The following is a description of a gene set: Any process that modulates the frequency, rate, or extent of a humoral immune response. Human Gene Set: GOBP_REGULATION_OF_HUMORAL_IMMUNE_RESPONSE species: Homo sapiens, and this is the list of marker genes: ZP4, SERPING1, SPNS2, PGC, C4BPB, VSIG4 (V-set and immunoglobulin domain containing 4), CR2 (complement C3d receptor 2), TNF, CXCL13, IL17F, CFH, C4BPA, SPINK5, FCGR2B, C3, PHB2, KLK5, TREM2, LTA, SUSD4, MIR520E, CD46, PTPRC, IL1B, KLK3, C1QBP (NCBI Gene Id 708), IL17A, PPP2R3C, CR1, CD5L (CD5 molecule like), HPX, ZP3, CCR7, CD37, FCER2 (Fc epsilon receptor II), PHB1, CD59, ACOD1 (NCBI Gene Id 730803), CD55, A2M, MASP1, FOXJ1, MIR520B, KLK7, PTPN6, CR1L, EVPL, GATA6